The following is a description of a gene set: Human Gene Set: REACTOME_FRS_MEDIATED_FGFR3_SIGNALING species: Homo sapiens FRS-mediated FGFR3 signaling, and this is the list of marker genes: FGF4, FGF20, FGF1, FRS2, FGF5, KRAS, FGF9, FGF16, HRAS, NRAS, FGF2, FGF8, GRB2, FGF17, PTPN11, FGF18, SOS1, FGF23, FGFR3, FRS3